Given this list of marker genes DSG1, DOCK8, SMAD3, STAT1, ARPC1B, TGFB1, TGFBR1 (NCBI Gene Id 7046), CARD11, TGFB3, JAK1, TGFBR2, TGFB2, STAT3, STAT6, here is a description of the gene set: Eosinophilic infiltration of one or more gastrointestinal organs. Gastrointestinal eosinophilia is a broad term for abnormal eosinophil accumulation in the GI tract, involving many different disease identities. These diseases include primary eosinophil associated gastrointestinal diseases, gastrointestinal eosinophilia in HES and all gastrointestinal eosinophilic states associated with known causes. Each of these diseases has its unique features but there is no absolute boundary between them. Gastrointestinal eosinophilia Human Gene Set: HP_GASTROINTESTINAL_EOSINOPHILIA species: Homo sapiens